The following is a description of a gene set: species: Mus musculus Mouse Gene Set: GOBP_NEGATIVE_REGULATION_OF_GENE_EXPRESSION Any process that decreases the frequency, rate or extent of gene expression. Gene expression is the process in which a gene's coding sequence is converted into a mature gene product (protein or RNA)., and this is the list of marker genes: Il4, Slc24a3, Dazl, Prkdc, Ddx4, Ptbp3, Mrpl13, Btbd18, Mir1a-1, Pou4f1, Brip1, Ufd1, Endou, Cd2ap, Gzmb, Mndal, Paip1, Oprd1, Prkar1a, Ubr5, Psen1, Pdcd4, Mir505, Ddx3y, Daxx, H2ac10, Gspt2, Tirap, Gja1, Prnp, Ajuba, Mir34b, Eif2ak4, Atp2b4, Hspa1b, Srsf6, Hnrnpd, Ndrg2, Npm1, Banf1, Ybx1, Sh3gl2, Nog, C1qbp, Zfp598, Cdh1, Mcrip1, Gas1, Dnajc3, Wnt11, Mir203, E2f1, Ndfip1, Gpatch3, Mir675, Piwil2, Mir450b, Wtip, Angel2, Sesn2, Clec4a2, Rbm3, Mbd3l1, Tnrc6a, Mir7-1, Prg4, Zpbp2, Ucn2, Exosc5, Eif4enif1, Lsm7, Dapl1, Lilra5, Cbx3, Ncbp1, Alkbh3, Mir668 (NCBI Gene Id 751523), Spag11a, Prkra, Abcc2, Rbm42, Hotair, Snx12, Tent5b, Zfp57, Hdac6, Hnrnpu, Ppp3ca, Rrp8, Ptpn11, Myd88 (NCBI Gene Id 17874), Twist1, Gspt1, Arid5a, Ppp1r15a, L3mbtl2, Tut1, Rps3, Clec4a3, Vegfa, Mir489 (NCBI Gene Id 723877), Thbs1 (thrombospondin 1), Mael, Smg8, Mir9-1, Scrib, Igf2bp2, Angpt1, Pdcd1lg2, Tent2 (terminal nucleotidyltransferase 2), Akt1, Mettl3, Ddx6, Zswim8, Nanos1, Ddrgk1, Paip2b, Suz12, Tusc2, Bmi1, Cnpy2, Samd4, Sirt2, Nptn, Pick1, Cd22, Kpna7, Hdac7, Dnd1, Mir10a, Upf2, Ssc5d, Mapt, Ppm1b, Ace, Bmp4, Akirin2, Cryab, Lhx2, Eif4g1, Ocln, Gata2, Mir100, Piwil4, Plekhn1, Hdac2, Vhl, Cuedc2, Tasor2, Lmnb2, Tex15, F2, Oas1d (2'-5' oligoadenylate synthetase 1D), Stox1, Mycs, Smyd5, Cidea, Mertk (MER proto-oncogene tyrosine kinase), Cnot1, Ptprc, Exosc7, C1qtnf3, Hnrnpk, Ccnb1, Pkp3, Sirpa, Ssb, Bbs2, Arrb1, Spink7, Robo1, Trp53cor1, Pdcd10, Parp9 (poly (ADP-ribose) polymerase family, member 9), Smg1, Lgr4, Twist2, Syncrip, Tspo, Gsk3b, Il1b, Csk, Tgfb1, Dgcr8, Laptm5, Mir7116, Zar1, Dmrt1i, Kdm5a, Ehmt1, Pphln1, Hspa1a (NCBI Gene Id 193740), Skic3, Rnf139, Rcor1, Malsu1, Skic8 (NCBI Gene Id 93803), Ptbp1, Bak1, Mul1, Tnp1, Prkn, Pglyrp4, Resf1, Mir26a-2, Cpeb4, Gm38999, Hnrnpa0, Il17a, Morc2b, Cnot3, Crkl, Tbrg4, Gper1, Srgn, Mir30a, Uty, Brf1, Smad2, Tyrobp, Pou2f1, Gba1, Ppp2cb, Pym1, Myt1, Mir223, Carlr, Mir449a, Ifi203, Tmf1, Pglyrp2, Ifnb1, Gapdh-ps15, Pole3, Xrn1, Calcr, Zc3h7b (zinc finger CCCH type containing 7B), Ehmt2, Magoh, Nanos3, Mir543, Extl3, Rad21, Eif2s1, Traip, Ccdc3, Mir24-2, Mbd3, Eif4e2, Mir200b, Gimap3, Axin1, Mir137, Nts, Atf6b, Aurka, Atoh8, Celf1, Exosc4, Dicer1, Serpinb1c, Zbtb7b, Cryba1, Plau, Errfi1, Serbp1, Mecp2, Slc11a1, Cx3cl1, Mir494, Tmem98, Hnrnpr, Lbr, Cpne1, Tdrd9, Aif1, Zbtb20, Il12b, Oas1g, Akr1c6, Bcl6, Vip, Mir495, Tdrd12, Dapk1, Pelo, H2al1f, Sgms1os1, Dcp1b, Vpreb3, Mir125a, Ins2, Wnt4, Morc1, Mir1a-2, Src, H2ap, Drosha, Adam10, Cldn3, Sirt4, Larp4b (La ribonucleoprotein 4B), Elob, Mir29c, Alkbh5, Tsku, Epm2a (epilepsy, progressive myoclonic epilepsy, type 2 gene alpha), Nudt16, Ing2, Tob1, Pycard, Cbx1, Mir98, Foxl2, Gbp4, Flot2, Bend3, Rsl1, Zfp36, Mir218-1, Baz1a (NCBI Gene Id 217578), Mir24-1, Srsf3, Gstp-ps, Havcr2, Cnot11, Exosc9, Unk, Tyms, Slc7a5, Ffar1, Atg9a, Tial1, Rbm15b, Hif1a, Lsm2, Apoa1, Mrto4, Il23r, Sftpd, Nlrp6, Sigirr, Arrb2, Casp3 (NCBI Gene Id 12367), Keap1, Eif4ebp1, Pabpc4, Dnmt3l, Fbxo24, Srsf7, Mir29a, Fmr1, Trim27, Lsm14a, Piwil1, Rgs2, Apobec3 (apolipoprotein B mRNA editing enzyme, catalytic polypeptide 3), Otud7b, Crebbp, Edc4, Wt1, Rc3h2 (NCBI Gene Id 77277), Zfp36l3, Dapk3 (death-associated protein kinase 3), Lgals9, Adar, Zc3h7a, Paip2, Xrn2, Zc3hav1, Mettl16, Suv39h2, Pnldc1, H2al1k, Gpr174, Mir96, Secisbp2, Pou5f1, Spout1, Clp1, H2al2b, Mir146, Ang5, Rest, Hnrnpc, Tdrd5, Lbp, Chmp1a, Tut7, Olfm1, Spocd1, Heyl, Trim37, Gdnf, Mir181b-2, Gtpbp2, Igf2bp1, Itgb8, Mov10, Mir702, Fermt1, Traf2, Lrp1, Rock2, Rbm33, Mir124a-1hg, Gata6, Mir449c, Casc3, Trip12, Map2k5, Parp16, Mefv (Mediterranean fever), Acvrl1 (activin A receptor, type II-like 1), Gimap5, Cldn19, Flt1, Rara, Mif, Celf4, Tgfb2, Morc2a, Vsig4, Ttc5, Tsnax, Slc35c2, Msr1, Nrde2, Mir361, Ggnbp2, Ythdc1, Parp3, Map3k20, Mir205, Tdrkh, H2al1n, Trim30a, Oas1b, Cyfip1, Pus10, Mir33, Gbp7, Cnot9, Shfl, Zar1l, Mir186, Mir370, Mir135a-1, Rbms3, H2al1o, Cd34, Oas1e, Tgfb3, Zfp410, Flt3, Ceacam1, Eif4a3, Ptpn22, Nbdy, Trub1, Lsm14b, Arg2, Tcf4, Apex1, Fgf15, Spen (NCBI Gene Id 56381), H2ab3, Shmt1, Cd46, Atf7ip, Nr0b2, Prdm14, Setdb2, Ctr9, Ifi208 (interferon activated gene 208), Etf1, Yap1, Nlrp12, Exosc3, Reg3g, Mir411, Ddx5, Rbm15 (NCBI Gene Id 229700), Rbl1, Pum1, H1f9, Nod2, Acin1, Bcdin3d, Ago3, Exd1, Dot1l, Relb, Mycn, Ptpn6, Lef1, H2al1b (NCBI Gene Id 100042927), Tnrc6b (trinucleotide repeat containing 6b), Srrt, Cnot7, Mir30c-2, Cd83, Prg3, Ctcf, Axin2, Cd96, Rnps1, Rbx1-ps, Lrrk2, Zmpste24, Smarca2, Nutf2-ps1, Pias4, Mir17, Ilf3, Mtpap, Atg5, Fxr2, Rc3h1, Ncl, Eif2ak1, Jak3, Ddx17, Eif4a3l2, Smarcad1, Snip1, H2al3, Nmnat2, Phf1, Rbl2, Zc3h14, Ifng, Irgm2, Lin28a, Nudt12, Chek1, Btk, Gas6, Ppara, Dis3, Il33, Rb1 (NCBI Gene Id 19645), Mir34a, Rbmxl1, Hnf1a, Slc2a10, Arg1, Sap18, Smg5, Tardbp, Hmgb2, Patl1, Anapc2, Bc1, Smg9, Nudt16l2, Mirlet7a-1, Glg1, Mir124a-3, Tut4, Skic2, Lrrc32, Meioc, Mir196a-2, Ppp1r11, H2ac23, Musk, Suv39h1, H2ac6, Nos2, Ltf, Rbm24, Ireb2, Ythdf3, Rack1, Mir539, Spin1, Wdhd1, Prmt5, Ilrun, Rac1, Twsg1, Pla2g10, Xcl1, Mir218-2, Caprin1, Kat5, Hells, Focad, Traf3ip1, Crh, Ncbp2, Oas1c, Tigit (T cell immunoreceptor with Ig and ITIM domains), Magohb, Slamf1, Cnot10, Xist, Epha2, Tnfrsf4, Mir204, Tent5a, Mir196b, Wfs1 (NCBI Gene Id 22393), Mir208b, Mir874, Hes1, Trp53inp1, Qki, Adipor2, Ovol2, Chrna7, Rgcc (NCBI Gene Id 66214), Eif2ak3, Map2k1, Irak3, Pibf1, Phf8, Cpb2, H2al2a, Ptbp2, Rnf125, Sox11, Pink1, Mir330, Max, Mir451a, Dnmt3b (NCBI Gene Id 13436), Apoe, Nfkbil1, Hand2, Cpeb2, Srp9, Oas3, Fn1, Zhx2, Arb2a, Aplnr, Wdr35, Tpr, Mir29b-1, Nckap1l, Rnasel, Mir511, H2ac1, Ager, Gzmc (granzyme C), Mir26b, Taf15, Upf1, Nup155, D1Pas1, Mir154, Hdac4, Srsf9, Ifi209, Mkks, Mir133a-1hg, Tgif1, Setdb1, Mir7-2, Spi1, Mir183, Klhl22, Elavl1 (ELAV like RNA binding protein 1), H2ac24, Mir875, Smad3, ENSMUSG00000126352, Ifi214, Insr, Ncbp3, Xpo5, Phf2, Bmpr1a, Axl, Epx (NCBI Gene Id 13861), Ddit3, Zfp281, Rbm8a, Sox9, Hdac9, Esr1, Ago4, Cnot6l, Cactin, Smo, Edc3, Rbm8a2, Wwp2, Dhx36, Rps13, Fastkd3, H2ac25, Tnrc6c, Furin, Myadm, Pan2, Inpp5e, Ezh1, Ffar4, Igf1, Nlrx1, Fastkd2, Edn1, Cnot2, Prkch, Cd276 (CD276 antigen), Mir134, Jak2, Polr2g, Supv3l1, Mir125b-2, Mir449b, Asz1, Otud5, Senp1, Macroh2a2, Dcp2, Mir133a-2, Il12a, Hras, Met, Mc1r, Epc1, H2ac4, Hnf4aos, Id3, Tdrd6, Pou3f2, Gstp2, H3f3a, Iqgap3, Fbln1, N6amt1, Anxa7, Noct, Mir324 (microRNA 324), Airn, Eprs1, Oas1h, Prdm1, Cmklr1, Pnrc1, Mir18, Il23a, Sirt6, Tcl1, Abcd2, Thrap3, Pde12, Inpp5d, Trib2, Apln, U2af2, Ptprs, Tle5, H2al1m, Serpinb1a, Dip2a, Ldlr, Rif1, H2ac7, Tent4b (NCBI Gene Id 70570), Ctla2a, Inhbb, Dhx34, Anxa4, Crhr2, Kmt2a, H2al1j, Rel, Zfp503, Fyn, Lmnb1, Mir21a, Btn2a2, H1f0, Tesk1, Ttbk1, Mir135a-2, H3f3b, Ago2, Cldn5, Emilin1, Mir217, Sirt1, Fgfr1, Ifi213, Gstp1, Ang, Eif4ebp2, Lsm6, Parp14, Smchd1 (NCBI Gene Id 791279), H2ac11, Eif2ak2, Atrx (ATRX, chromatin remodeler), Cd59a, Fastkd5, Stat3, Upk3b, Brca1, Ybx2, Mir504, Ftx, Samd4b, Homer3, Ddx56, Bahd1, Adipoq, Homer2, Gapdh, Mir423, H2ac12, Creb3l1, Syt11, Spty2d1, Kcnq1ot1, Mirlet7a-2, Mir15a, Lsm1, Trp53, Pcgf3, Pabpn1l, Fastk, Prkaa1, Apoa2, Cdk2, Scgb1a1, Slit2, Mir155, Pcbp4, Hfe, Tiparp, Chid1, Mir124a-1, Calr, Ccl3, Tent5c, Fkbp6, Tex19.2, H2ax, Parn, Socs5, Il20rb, Pla2g3, Morc3, Mir466l, Laptm4b, Eif6, Mir301, Mir448, Mir338, Eif1, Macroh2a1, Upf3b (NCBI Gene Id 68134), Sap18b, Msx1, Klf4, Traf5, Gapdhrt2, Akt2, Lilrb4b, H2ac22, Mir470, H2al1e, Tdrd7, Lsm4, Trim6, Kat8, Oas1f, Prg2, Vim, Mir29b-2 (NCBI Gene Id 723963), Fam76b, Parp10, Cx3cr1, Gata4, Rbm47, Pparg, Apobec1, Bst2, Elf4, Tnfrsf21, Mir143, Sry, Mir124-2hg, Abcd1, Ins1, Klf2, App, Mta1, Nlrp3, Mir1247, Gpat2, Ddx3x, Atp2b1, Tdrd1, Selenos, Cacng7, Inppl1, Adcy7 (adenylate cyclase 7), Zc3h12a, Grb7 (growth factor receptor bound protein 7), Bcl3, Rock1 (NCBI Gene Id 68785), Fxr1, Lin28b, Mex3d, Scmh1, Oas1a, Ppm1d, L3mbtl1, Ifrd2, Prr5l, Dap, Smad7 (SMAD family member 7), Pnrc2, Smg7, Rida, Ern1, Foxj1, Tent5d, Dyrk1a, Mir182, Tsix, Appl2, Pkp1, Nme1, Ccn2, Rbx1, Il1rl1, Ncor1, Agt, Cenpv, Snd1, Rlim, Ifi206, Smad5, Gpr18, Limd1, Mir351, Mettl14, Zfp869, Prkca, Pcid2, Akap8, H2aj, Eif2a, Eif4e, Bmp2, Eif4a3l1, Zc3h12d, Zfpm1, Mirlet7c-1, Rbm46, Mir34c, Nanos2, Olr1, Gata5 (GATA binding protein 5), Rnaseh2b, Aff2, Slc37a4, Traf3ip2, Prkaa2, Mapkapk2, Id1 (inhibitor of DNA binding 1, HLH protein), Mir140 (microRNA 140), H2ac15, Uhrf1, Pomc, Dcp1a, Nfkb1, Mir23a, Pura, Smarca5, Cul3, Nlrc3, Mir214, Ezh2, Cited2, Sirt7, Cpeb1, Mirlet7c-2, Tnf, H2ac21, Gstp3, Il1r2, Kmt2d (NCBI Gene Id 381022), Cd24a (CD24a antigen), Slit3, Hinfp, Wnt8b, Otud6b, Fgfr3, Henmt1, Elavl4, Chd4, Rpl13a, Mir200a, Cdk1, Cdyl, Zc3h10, Pgr, Mir3960, Apod, Smarca4, Pml, Il6, Hdac1, Tbx21, Siglecg, Rps26, Siglec1, Cirbp, Nr1h4, Pnpt1, Exosc10, Uhrf2, Dll4 (delta like canonical Notch ligand 4), Exosc8, Mir382, N4bp1, Lrp3, Mbd3l2, H2ac19, Tlr8, H2ab1, Caprin2, Trem2, Atm, Hbs1l, Hsf1, Gpnmb, Rbm4, Phf19, Hnrnpab, Cd200r1, H2ac13, Pglyrp3, Pawr, Plat, Tlr4, Irgm1, Kdr, Acp4, Vegfb, Xbp1, Sfrp2, Rlf, Mir196a-1, Dysf, Fto, Mir219a-2, Hdac5, Il13ra2, Sfswap, Ubr2 (ubiquitin protein ligase E3 component n-recognin 2), Erp29, Atg12, Yy1, Mirlet7e, Ago1, Elane, Xdh, Gigyf2, Cdkn1a, Mir26a-1, Ctsz, Cptp, Eloc, Pdgfb, Igfbp5, Mir129-2, Nav3, H2ac20, Pus7, Nicol1, Usp7, Hey1, Tbk1, H19, Mis18a, Cd36, Ythdf1, Mbd1, H2az1 (NCBI Gene Id 51788), Ctif, Picalm, Srsf1, Aqp4, Ripk1, Mirlet7g, Mvk, Exosc2, Slfn14, Ccr1l1 (NCBI Gene Id 12770), Mphosph8, Trim28, Gtpbp1, Nutf2, Acp5, Il27ra, Mettl4, Patl2, Mir101a, Clec4a4, Anxa1, Nploc4, Zfp148, Fgfr4, Tgfbr3, Stc2, Mtor, Igf2bp3, Tlr2, Btg2, Ucn, Plag1, Mir30c-1, Hat1, Tert, Pik3cd, Bank1, Bbs4, Serpinf2, Bcl11a, Peli3, Tnfrsf1a (tumor necrosis factor receptor superfamily, member 1a), Id2, Habp4 (NCBI Gene Id 80586), Carhsp1, Sh2d1b1, Myc, Fus, Mir21c, Mlh1, Serpine2, Ghrl, Zfp36l2, Gzmn, Cnot8, Baz2a, Dubr, Kat2b, Fcgr2b, Dhx9, Ccr7, Mir107 (NCBI Gene Id 723826), Mir124a-2, Dnmt1, Larp1, BC037156, Foxp1, Eri1, Sars1, Rabgef1, Mapkbp1, Hdac3, Ifi203-ps, Mef2c, Pld6, Foxp3, Rbm38, Cilp, Eed, Acvr1b, Mbd2, Jarid2, Sin3a (transcriptional regulator, SIN3A (yeast), NCBI Gene Id 20466), Pcif1, Ndfip2, Trim71, Serpinb1b, Notch1 (notch 1), Sfmbt2, Mir125b-1, Ctnnb1 (NCBI Gene Id 12387), A1cf, Usp17le (ubiquitin specific peptidase 17-like E), Pcgf5, Dll1, Parp1, Gas5, Znfx1, Mov10l1, Enc1, Vsir, Fastkd1, Mir219a-1, Tmbim6, Il36rn, Mir1b, Mirlet7b, Dhx58, Igtp, Mir133a-1, Pan3, Cpeb3, Pglyrp1, Ifi207, Samd7, Dis3l, Nr1h2, Srsf4, Cbx8, Lilrb4a, Helz2, Pabpc1, Shh, Dgkq, Hnrnpa2b1, Dxo, Cd3e, Mir296, Macir, Cnot6, Mir144, Nkx3-1, Cd28, Hmga2, Kmt2b, Il13, Serpine1, Kdm4a, Mir221, Kdm2a, Muc16, Serpinf1, Il10, Ptrh2, Mir451b, Kantr, Tsn, Ythdf2, Hmox1, Rnf128, Ptger4, Mir101b, Cd84 (NCBI Gene Id 320559), Csdc2, Mir320, Pum2, Rxra (NCBI Gene Id 78740), Mir541, Khsrp, Map3k7, Mir7578, Zfp36l1, Helz (NCBI Gene Id 78455), Eng, Ros1, Creb1, Pik3ca, Mir181b-1, Jpx, Gtsf1, Notch2, Rbm10, Dis3l2, Ephb2, Dcps, Nudt16l1, Tnfaip3 (NCBI Gene Id 21929), Hgf, Zfp683, Smarca1, Tnfsf4, Xaf1, Il22, Nrxn1, Bap1, Hspa4, Hdac8, Rbm20, Tlr6, Chaserr, Zcchc7 (NCBI Gene Id 319885), H2ac8, Boll, Srsf10, Upf3a, Smcr8, Cryaa, Il22ra1, Cbx5, Zfy2 (zinc finger protein 2, Y-linked), Tfap2c, F2rl1, Chac1, Phb1, Smg6, Cd200, Tarbp2, Ncor2, Vps35, Mir129-1, Zfp445, Prdm4, Lgmn, Tia1, Nmb, Bmyc (brain expressed myelocytomatosis oncogene), Mdm2, Ikbke, Mtf2, Bpi, Park7, Nmi, Gata3, Sfrp1, Mir21b, Nmbr, Lag3, Git1, Sdr16c5, Adnp, Lrif1, Tasor, Dnmt3a, Mir873a, Celf2, H2ab2 (NCBI Gene Id 635264), Terf2, H2az2, Acod1, Ido1, Mark1, Ticam2, C5ar2, Erbin, Gapdhrt, Csde1, Pias3, Cd274, Ezr, Tsc1, Nbas, Map2k2, Crebzf, Eif3e, Pcx, Lsm5, Lmna, Exosc6, Fbxw7, Tex19.1, Ghsr, Eif4ebp3, Tent4a, Ccr1 (C-C motif chemokine receptor 1), Hmgb1, Pmp22, Hey2, Mir7b